The following is a description of a gene set: Microarray analysis was performed to determine the transcriptional profiles of NKT, CD1d-aGC+ Va24-, and CD4 T cells. Genes down-regulated in activated T cells: CD4 versus NKT. species: Homo sapiens Human Gene Set: GSE28726_ACT_CD4_TCELL_VS_ACT_NKTCELL_DN from publication Constantinides MG, Picard D, Savage AK, Bendelac A (PMID 21632718), and this is the list of marker genes: EIF1, UBE2B, SARAF, WTAP, ELF1, SRGN, RPS10, ZNF101, EPHB6, CTBP1, AUTS2 (NCBI Gene Id 26053), SF3A1, PRPF18, PPM1H (NCBI Gene Id 57460), PNISR, SDCBP, EZR, LITAF, TERF1, HEG1, ABLIM1, OGFR, DGKA, TXNIP, CXCR4, JAK1, JADE2, BBIP1, TRAPPC12, FCGRT, TMEM131L, AKAP17A, MGRN1, HNRNPH1 (NCBI Gene Id 3187), PRKCQ, KAT7, THUMPD1, SGK1, ZBTB18 (zinc finger and BTB domain containing 18), PAN2, H1-10, RPL31, LSM14A, CIAPIN1, TRAF3IP2, ITGA6, CYTH1, ARHGEF18, TRIB2 (NCBI Gene Id 28951), RFX5, FCHSD2, H3-3B, RGS2, S1PR4, CD37, TBX19, MNT, IKBKG, PGRMC2, SSR4, PPP2CA (NCBI Gene Id 5515), SATB1, SORL1, SIK1, CCDC69, BCL2L11, ADD3, NSFL1C, HNRNPH2, RBM39, PLK3 (NCBI Gene Id 1263), TOB1, PER1, SLC2A3, RPS29, IL11RA, ARHGAP45, HOXA5, NUMA1, CLN3, DDX5, GADD45A, IL6ST, ZAP70, SRSF5, DENND5A, SNRK, TNFAIP3, TLE5, CALM1, SNRNP70, RGS1, UBE2J1, KDM3A, HERC2P3, DNAJB1, RCE1, ARL2BP, MYCNOS, S1PR1, PDE4D, RNF44, MAL, ITPKB, TLK1, HLA-E, CYLD, BCLAF1, B3GALT4, ENTPD6 (ectonucleoside triphosphate diphosphohydrolase 6), SGSM2, CLK1, RBL2 (NCBI Gene Id 5934), SERINC5, TSN, TPP1, MID2, SDR39U1, DUSP8, TUBA1A (NCBI Gene Id 95407), DGCR2, JUNB, BLCAP, CHD3, TNK2, RPL29, CDIPT, RPL38, TOE1, BTG2, HDAC5 (histone deacetylase 5), RPS27, AXIN1, ARFGAP2, KDM2A, ATXN7L3B, STK17A, MAN2A1 (mannosidase alpha class 2A member 1), CIRBP, TRAM2, LAMP1, DGKZ, MAPRE3, PDE4B, MOAP1, RPL37A, NXF1, JOSD1, RANBP2, EIF3A, STK10, BTG1, NFATC2IP, GPS2, RASGRP2, TPT1, TSC2, TAOK3, UBA7, SH3YL1, ADA, SLC7A6, VPS8, ZNF428, CASP4, PLAAT4, SUPT4H1, FYB1, FCMR, RBM38 (RNA binding motif protein 38), COL21A1, INPP5D, DDIT3, SRSF6, BICRAL, FTH1, BCL11A, RNF139, ARL4C, UBXN1, HBP1, ATP6V1G1, ARHGAP4, NCOA1, HNRNPDL, ST3GAL6, RBMS1, CDC14A, LAPTM5, HNRNPH3 (heterogeneous nuclear ribonucleoprotein H3), NUCB2, DNAJB6, MT1A, AFF1, ATG13, H2AC17, MXI1, TPM2, SEC31B